Given this list of marker genes ATP5F1D, ATP5MG, ATP5MJ, ATP5MK (ATP synthase membrane subunit k), ATP5F1A, MT-ATP6, MT-ATP8, ATP5MC2, ATP5F1C, ATP5MC1, ATP5F1B, ATP5PO, ATP5MC3, ATP5PD (ATP synthase peripheral stalk subunit d), ATP5MF, DMAC2L, ATP5PB, ATP5ME, ATP5PF, ATP5F1E, here is a description of the gene set: studied in species Homo sapiens Human Gene Set: REACTOME_FORMATION_OF_ATP_BY_CHEMIOSMOTIC_COUPLING Formation of ATP by chemiosmotic coupling